The following is a description of a gene set: Mouse Gene Set: MIR_7665_3P species: Mus musculus Genes predicted to be targets of miRBase v22 microRNA mmu_miR_7665_3p in miRDB v6.0 with MirTarget v4 prediction scores > 80 (high confidence targets). from publication Chen Y, Wang X (PMID 31504780), and this is the list of marker genes: Esco2, Cdk5rap2, Tmc5, Nlgn2, Hook3, Cypt14-ps, Tstd2, St6galnac4, Gpr157, Cux1, Brcc3, Wrnip1, Dhdds, Cbln2, Lyrm7, Kbtbd8, Uba2, Ctnnd1, Cbx6, Pank2, Kcnb1 (potassium voltage gated channel, Shab-related subfamily, member 1), Cdipt, Luc7l (Luc7-like), Hic1 (NCBI Gene Id 15248), Fzd8 (frizzled class receptor 8), Naa60, Orc5, Heatr6, Pacs1, Ranbp10, Ggcx, Layn, Pros1 (NCBI Gene Id 19128), Shisa9, Chn1, Ap4b1, Pnkd, Kcnip1, Klf6, Arhgap27, Mettl23, Abhd12, Trabd2b